The following is a description of a gene set: species: Homo sapiens Reactome Pathway: alectinib-resistant ALK mutants Alectinib is a second generation tyrosine kinase inhibitor that is approved for use in ALK positive non-small cell lung cancers (NSCLCs). Alectinib is effective against a number of ALK mutants that arise after treatment with crizotinib, however resistance to alectinib has also been reported. This pathway describes ALK mutants that are resistant to inhibition with alectinib. part of: Drug resistance of ALK mutants, and this is the list of marker genes: ALK